The following is a description of a gene set: Human Gene Set: GOBP_PROTEOGLYCAN_CATABOLIC_PROCESS studied in species Homo sapiens The chemical reactions and pathways resulting in the breakdown of proteoglycans, any glycoprotein in which the carbohydrate units are glycosaminoglycans., and this is the list of marker genes: BTK, HEXA, HYAL1, GNS, ADAMTS12, GUSB, HEXB, SGSH, ADAMTS4, IDUA, HPSE, IDS, HGSNAT, GPC1, GLB1, HYAL4, NAGLU (N-acetyl-alpha-glucosaminidase)